Given this list of marker genes Ralgapa1, Adgrg3, Foxh1, Setd6, T, Nod2, Arrb2, Kdm1a, Commd7, Spop, Pkhd1, Id1, Adora3, Parp10, Cdk5rap3, Pias2, Pura, Nfkbid, Cyld, Pex14, Trib2, Glis2, Ezh2, Ikbip, Prox1, Ptgis, Sp100, Hdac2, Men1, Sik1, Pycard, Sfrp4, Pim1, Wwp2, Bcl3, Msx2, Nfkbia, Tnfsf4, Ndn, Bhlhe40, Gfi1, Nr0b2, Igf1r, Eif2ak4, Irak2, Prdx2, Mad2l2, Traip, Lrrc14 (NCBI Gene Id 223664), Peli1, Klf4, Cdkn2a, Nlrc5, Chuk, Sirt1, Egln1, Cyp1b1 (cytochrome P450, family 1, subfamily b, polypeptide 1), Cactin, Erbin, Trim37, Foxp3, Aim2, Eomes, Ddit3 (NCBI Gene Id 13198), Irak1, Commd1, Nupr1, Otulin, Usp7, Rwdd3, Paxip1, Nlrp12, Esr1, Pla2g10, Zc3h12a, Rlim, Map3k10, Cat, Cys1, Ppp2cb, Acod1 (NCBI Gene Id 16365), Foxj1, Irak3, Mturn, Taf3, Kat6a, Cd200, Spi1, Rbck1, Tnfaip3, Tax1bp1, Hdac4 (NCBI Gene Id 208727), Hand2, Trim40, Fzd6, Cebpg, Pbx1, Tcf7l2, Nwd1, Hdac3, Zfp932, Commd6, Hand1, Tnfrsf4, Foxs1, Heyl, Id3, Traf3, Pthlh, Anxa4, Itch, Tbx6, Nr0b1, Pias4, Chp1, Nr1h4, Tceal7, Ctnnbip1, Tut4, Tmigd3, Havcr2, Rnf2, Sumo1, Trib1, Brms1, Trim21, Phb2 (prohibitin 2), Foxa2, Arrb1, Nfkbil1, Dnaja3, Flna, Id2, Dap, Siva1, Ptch1 (patched 1), Dab2ip, Nlrc3, Psmd10, Pou4f2, Cmklr1, Prmt2, Xcl1, Ufl1, Med13, here is a description of the gene set: Mouse Gene Set: GOBP_NEGATIVE_REGULATION_OF_DNA_BINDING_TRANSCRIPTION_FACTOR_ACTIVITY studied in species Mus musculus Any process that stops, prevents, or reduces the frequency, rate or extent of the activity of a transcription factor, any factor involved in the initiation or regulation of transcription.